Given this list of marker genes GGT5, CCND2, CD1B (CD1b molecule), AURKA, TNF, IL6, SLAMF1, HIRIP3, CD180, ALAS1, PFKP, IL1RN, GML, LGALS2, ADGRB3, TPI1, FANCG, INHBA, ARHGAP29, RNASEL, NTN1, here is a description of the gene set: Human papillomavirus (HPV) virus-like particle (VLP) vaccines were recently licensed. Although neutralizing Ab titers are thought to be the main effectors of protection against infection, early predictors of long-term efficacy are not yet defined and a comprehensive understanding of innate and adaptive immune responses to vaccination is still lacking. Here, microarrays were used to compare the gene expression signature in HPV-16 L1 VLP-stimulated PBMCs from 17 vaccine and 4 placebo recipients before vaccination and 1 mo after receiving the second immunization. Vaccination with a monovalent HPV-16 L1 VLP vaccine was associated with modulation of genes involved in the inflammatory/defense response, cytokine, IFN, and cell cycle pathways in VLP-stimulated PBMCs. Additionally, there was up-regulation of probesets associated with cytotoxic (GZMB, TNFSF10) and regulatory (INDO, CTLA4) activities. The strongest correlations with neutralizing Ab titers were found for cyclin D2 (CCND2) and galectin (LGALS2). Twenty-two differentially expressed probesets were selected for confirmation by RT-PCR in an independent sample set. Agreement with microarray data was seen for more than two-thirds of these probesets. Up-regulation of immune/defense response genes by HPV-16 L1 VLP, in particular, IFN-induced genes, was observed in PBMCs collected before vaccination, with many of these genes being further induced following vaccination. In conclusion, we identified important innate and adaptive response-related genes induced by vaccination with HPV-16 L1 VLP. Further studies are needed to identify gene expression signatures of immunogenicity and long-term protection with potential utility in prediction of long-term HPV vaccination outcomes in clinical trials. Genes positively correlated with antibody response in peripheral blood mononuclear cell in young adults (18-25) after exposure to HPV-16 L1 VLP, time point 7M. Comment: Spearman Correlation of Gene Expression with Neutralizing Antibody Levels Human Gene Set: GARCIA_PINERES_PBMC_HPV_16_L1_VLP_AGE_18_25YO_7MO_CORRELATED_WITH_ANTIBODY_RESPONSE_POSITIVE from publication García-Piñeres AJ, Hildesheim A, Dodd L, Kemp TJ, Yang J, Fullmer B, Harro C, Lowy DR, Lempicki RA, Pinto LA (PMID 19155521) studied in species Homo sapiens